Given this list of marker genes NDST4, MRPL46, KCTD7, OIP5, OPTN, SMCHD1, STAM, PTK2, MAZ, RTCA, TOP2B, VSTM2B, SAPCD2, ACTN4, MRPS27, FAF1 (NCBI Gene Id 112268262), CAPRIN1, TMEM201, PFN2, MED18, KATNB1, GCOM1, CBX4, POLR3H, GCLC, GET4, ROPN1L, NUTF2, PSMD1, PRPF19, DPP3, TUBGCP2, USP28, SMAP1, CHAMP1, DTNA (dystrobrevin alpha), SAE1, N4BP3, IFT172, RBBP4, TMEM164, PCYT2, HSPA12B, VWA7, PPP1R8, MEN1, ZNF354A, SMCO4, ADARB1, TIMM17B, TMCO4, COL25A1, C3orf38, INTS15, C19orf47, NUP62, DYNLL2, BAG2, MTTP, RBBP5, PRPS2, UBA3, DTD2, SYMPK, IBTK, LMAN1L, HIRA, PITPNC1, HDAC1, SKIC3, MRPL10, SELENOP, SLC35F2, PIGF, NUP58, UBAP2, NELFB, PPP6C, HDAC2, TMEM138, ENPP1, TGFBR1, FABP5, VPS35, E2F2, CHMP6, UBE2E1, POMGNT1, METTL9, GMPS, METAP2, ZFAT, IPO5, PSMD3, WDR12, PGK1, SLC1A4 (solute carrier family 1 member 4), MRPL3, ZNF496, FIZ1, RNF10, FAM98B, PTER, PCM1, RAD18, MRPL20-AS1, TCERG1, SSRP1, BMP10, HNRNPK, GSK3A (glycogen synthase kinase 3 alpha), EIF5A, HDAC6, EPN1, HCFC1, PALM, DNAI4, ETFA, C9orf40, SORD, CYB5R4, HES6 (hes family bHLH transcription factor 6), ELMO2, GPD1L, COL15A1, SCRIB, ZDHHC6 (NCBI Gene Id 64429), LAMTOR2, RTN4IP1, ZMAT2, ZC3H14, SNX25, LMO7, PDE2A, PSMC2, EIF4G2, HNRNPM, LSM1, HNRNPAB, MAST2, TTLL5, CENPV (centromere protein V), PPIL1, PLD6, PMS2, USP37, IMMT, GNB3, INTS13, MED24, AMIGO1, VPS4A, FKBP1A, B3GAT1, MTHFD1L (methylenetetrahydrofolate dehydrogenase (NADP+ dependent) 1 like), TMEM181, CENPO, VSX2, C16orf87, DDX19A, PAFAH1B3, TTF2, SCN11A, G3BP1, RELN, CYP20A1, TMBIM1, CNKSR3, DELE1, MYOM1, TPST1, FAM167B, DDB1, MAJIN, SUMO3, MTM1, PFKM, ANKRD54, RHBDL2, WDR70, FYTTD1, RAB5IF, FGFBP3, RUVBL1, MAP7D1, SYCE3, CS, KLHL41, TOMM22, SMAD1 (NCBI Gene Id 4086), E2F4, SURF6, TMEM63A, TRPC4AP, SLC25A13, TRIM35, TTC9C, SATB2, DNAJC10, CDK2AP1, here is a description of the gene set: Genes down-regulated in dendritic cells: CIITA knockout versus I ab-/- mice. Human Gene Set: GSE557_CIITA_KO_VS_I_AB_KO_DC_DN Triplicates preparations of RNA from day 10 DC's. Experiment is described in Wong et al 2003 Nat. Immunol. species: Homo sapiens from publication Wong AW, Brickey WJ, Taxman DJ, van Deventer HW, Reed W, Gao JX, Zheng P, Liu Y, Li P, Blum JS, McKinnon KP, Ting JP (PMID 12910265)